Given this list of marker genes RB1, COX7B, NDUFB11, HCCS, HLA-A, here is a description of the gene set: Vitritis Human Gene Set: HP_VITRITIS studied in species Homo sapiens Inflammation of the vitreous body, characterized by the presence of inflammatory cells and protein exudate in the vitreous cavity.